Given this list of marker genes Psma6 (proteasome subunit alpha 6), Relb, Card9, Psmd7, Psmb5, Tab2, Psmc2, Ubb, Psmd6 (NCBI Gene Id 66413), Malt1, Psmc6, Nfkbia, Psmb6, Calm1, Psma1, Map3k14, Tab1, Psmd1, Ube2v1, Psmb4, Ube2d1, Casp8, Psmc4, Psma4, Psma5, Cdc34 (cell division cycle 34), Tab3, Psmb7, Psmd13, Psmc3, Cul1, Pdpk1, Psma2, Psmc1, Rela, Psmc5, Ikbkb, Nfkb2, Psma7, Pycard, Ppp3r1, Psma3, Rps27a, Psmd12, Nfkb1, Ube2n, Plcg2, here is a description of the gene set: electronically inferred by orthology from the curated human pathway species: Mus musculus Reactome Pathway: CLEC7A (Dectin-1) signaling part of: C-type lectin receptors (CLRs) This event has been computationally inferred from an event that has been demonstrated in another species.<p>The inference is based on the homology mapping from PANTHER. Briefly, reactions for which all involved PhysicalEntities (in input, output and catalyst) have a mapped orthologue/paralogue (for complexes at least 75% of components must have a mapping) are inferred to the other species.